Given this list of marker genes MTF1, SLC39A8, COMP, IFT80, CYTL1, here is a description of the gene set: A tissue homeostatic process involved in the maintenance of an internal equilibrium within cartilage, including control of cellular proliferation and death and control of metabolic function. species: Homo sapiens Human Gene Set: GOBP_CARTILAGE_HOMEOSTASIS